The following is a description of a gene set: studied in species Mus musculus This event has been computationally inferred from an event that has been demonstrated in another species.<p>The inference is based on the homology mapping from PANTHER. Briefly, reactions for which all involved PhysicalEntities (in input, output and catalyst) have a mapped orthologue/paralogue (for complexes at least 75% of components must have a mapping) are inferred to the other species. part of: Regulation of T cell activation by CD28 family Reactome Pathway: Co-stimulation by ICOS electronically inferred by orthology from the curated human pathway, and this is the list of marker genes: Pik3r2, Icosl (icos ligand), Pik3cb, Pik3r5, Icos